Given this list of marker genes IGKC, IGHA1, IGKV3-11, IGHV4-59, IGKV3-15, IGHV3-48, IGKV3-20, IGKV1-39, IGHG2, IGKV1-12, IGHV3-74, IGLV1-44, IGKV1-5, IGKV2D-28, IGHV3-7, IGHG1, here is a description of the gene set: from publication Salvador-Martín S, Kaczmarczyk B, Álvarez R, Navas-López VM, Gallego-Fernández C, Moreno-Álvarez A, Solar-Boga A, Sánchez C, Tolin M, Velasco M, Muñoz-Codoceo R, Rodriguez-Martinez A, Vayo CA, Bossacoma F, Pujol-Muncunill G, Fobelo MJ, Millán-Jiménez A, Magallares L, Martínez-Ojinaga E, Loverdos I, Eizaguirre FJ, Blanca-García JA, Clemente S, García-Romero R, Merino-Bohórquez V, González de Caldas R, Vázquez E, Dopazo A, Sanjurjo-Sáez M, López-Fernández LA (PMID 33429950) Genes downregulated in anti-TNF therapy non-responders vs. responders after two weeks of anti-TNF therapy species: Homo sapiens Human Gene Set: SALVADOR_MARTIN_PEDIATRIC_TBD_ANTI_TNF_THERAPY_NONRESPONDER_POST_TREATMENT_DN Background: Up to 30% of patients with pediatric inflammatory bowel disease (IBD) do not respond to anti-Tumor Necrosis Factor (anti-TNF) therapy. The aim of this study was to identify pharmacogenomic markers that predict early response to anti-TNF drugs in pediatric patients with IBD. Methods: An observational, longitudinal, prospective cohort study was conducted. The study population comprised 38 patients with IBD aged < 18 years who started treatment with infliximab or adalimumab (29 responders and nine non-responders). Whole gene expression profiles from total RNA isolated from whole blood samples of six responders and six non-responders taken before administration of the biologic and after two weeks of therapy were analyzed using next-generation RNA sequencing. The expression of six selected genes was measured for purposes of validation in all of the 38 patients recruited using qPCR. Results: Genes were differentially expressed in non-responders and responders (32 before initiation of treatment and 44 after two weeks, Log2FC (Fold change) >0.6 or <_0.6 and p value < 0.05). After validation, FCGR1A, FCGR1B, and GBP1 were overexpressed in non-responders two weeks after initiation of anti-TNF treatment (Log2FC 1.05, 1.21, and 1.08, respectively, p value < 0.05). Conclusion: Expression of the FCGR1A, FCGR1B, and GBP1 genes is a pharmacogenomic biomarker of early response to anti-TNF agents in pediatric IBD.